Given this list of marker genes MESP1, FOXH1, AXIN2, LRP2, RBPJ, ISL1, MEF2C, WNT11, SMARCD3, BMP4, WNT5A, here is a description of the gene set: The process that results in the delineation of a specific region of the lateral mesoderm into the area which will form the majority of the mesodermal component of the right ventricle, arterial pole (outflow tract) and venous pole (inflow tract). species: Homo sapiens Human Gene Set: GOBP_SECONDARY_HEART_FIELD_SPECIFICATION